Given this list of marker genes SLC25A25, ELOVL5, XPNPEP3, PRELID1, NR2E1, MBIP, AVPI1, ING4, PAK1, GEM, NUP42, HAS1, FLT1, PNMA3 (NCBI Gene Id 91916), UMPS, SCAMP5, ORMDL2 (NCBI Gene Id 94102), ADNP, NUBPL, RBMS2, MAPK10, EEF2, RPS29 (NCBI Gene Id 6235), SUV39H2, GPM6B, DDX51, CBX8, OSBPL9, IFT20, HS3ST2, HS3ST3A1, ZC3H10, ALS2, TNFAIP1, CHPF, ABCE1, DNAJC27, NOL4, CYSTM1, GPR3, SEMA4C, VPS37B, RNF7, TAOK2, YTHDC2, DUSP1, PLCD3, AFF4, SENP2, TRAF4, THOC1, ELL2, ATL2, ZNF516-DT, SREBF2, MYL6, ZMYND15, ZBTB21, ZNF367, DEPDC4, CFAP68, JUND, TH, MCAM, FAM174A, CCNA2, PKP4, TMEM59L, CLDN7, ARL4D, DHX36, AHI1, IKBKB, TUBB2B, BNIP3L, PDP1, TEX14, GTF3C1, SPATA7, OSR1, PLK4, CAMK2D, XRN2, ANAPC10 (NCBI Gene Id 25866), RUSC1, SARNP, PPARGC1A, RAD51C, TP53INP2, RIPK4 (receptor interacting serine/threonine kinase 4), DDX28 (DEAD-box helicase 28), NF1, WNT10A, AKIRIN1, KCTD8, NDUFA10, RUNDC3A, PEG3, RALGAPA1P1, RAB24, MAOA, ELAVL1, ZBTB37, HDX, OGDH, NCALD, RIPOR1, CTC1, RBKS, ZNF576, RAB6A, PNMA6A, GNB4, SYT11, ZNF184, MMGT1, PACRGL, MITF, CNTROB, ZNF593, IRX4, PNRC1 (NCBI Gene Id 10957), ZNF687, HSP90AB1, ATF3, PCSK1, CDC42, DGUOK, DCTN1, TMUB2, MRGPRF, NOC4L, EPB41, CALM2, KCNF1, SGIP1, MRRF, PRR3, YWHAZ, CENPE, NDUFB2, INTS7, CHGB, SST, RBP5, ZBTB11, ATG5, TMEM147, CLDN6, APPBP2, GLOD4, PFAS, DNTTIP1, GPBP1, DDX19A, G3BP2 (G3BP stress granule assembly factor 2), CXCL16, MLF2, UCN, CCN4, CREM, CHMP1B, NR4A2, SLC18A2, CD2AP, STAT3, PDLIM3, PPM1A, TBC1D32, SIK1, ADAP1, LMCD1, IRX6, NUP214, FOXD3, SPAG9, CHMP2A, TSC22D2 (NCBI Gene Id 9819), TSPAN7, PAFAH1B1, TGIF2, EPHA2, MAFF, CCDC148, ZMYM2, CDX4, MBNL2, PPP2R2A, RPL41, PER1, CMSS1, UBE2H, LTBP1, C11orf87, NUP98, FAM131A, NEUROD6, VGF, LDHA, KICS2, MRM3, RAB25, H4C5, GNL1, RBM18 (RNA binding motif protein 18), CRH, ADNP2, RCAN1, MAP3K13, CLSTN3, ZFAND2B, SDHB, CDS1, AREG, PARD6A, RNF44, RPRD1A, RAI1, MAF, RCE1, PHACTR3, DAAM2, SNAP25, BABAM2, PPP1R15A, DIO2, ST13, WFDC3, SLC38A1, TMEM39A, THADA, ATP6V0C, ID1, HHIP, ZNF335, IRF2BPL, ASPHD1, SYNGR3, MAP1LC3A, KYAT1, LGR5, PITX2 (paired like homeodomain 2), HOXC10, ARIH1, DUS2 (NCBI Gene Id 54920), RELB, CYLD, USP48, RUSC1-AS1, FGF6, FOSB, TRAP1, TIPRL, PTPRU, SULT4A1, SCG2, SIDT2, SRRM4, CDK2AP2, SLC35F5, ZFYVE27, ABHD16A, GLI1, ZIM2 (NCBI Gene Id 23619), BRAF, C1orf35, ADCY8, KCNA5, here is a description of the gene set: Human Gene Set: CREB_01 studied in species Homo sapiens Genes having at least one occurrence of the motif TGACGTMA in the regions spanning 4 kb centered on their transcription starting sites. This matches the CREB1 transcription factor binding site V$CREB_01 (v7.4 TRANSFAC).